The following is a description of a gene set: studied in species Mus musculus part of: Mitotic G1 phase and G1/S transition Reactome Pathway: G1/S Transition electronically inferred by orthology from the curated human pathway This event has been computationally inferred from an event that has been demonstrated in another species.<p>The inference is based on the homology mapping from PANTHER. Briefly, reactions for which all involved PhysicalEntities (in input, output and catalyst) have a mapped orthologue/paralogue (for complexes at least 75% of components must have a mapping) are inferred to the other species., and this is the list of marker genes: Rps27a, Psma7, Cables1, Psmc3, Mcm8, Mcm7, Cdc6, Psmb7, Psmb6, Psmb4, Pole, Psmc2, Psmc6, Psmd1, Psmc5, Cdkn1b, Psmd7 (NCBI Gene Id 17463), Ccna1, Prim1, Psmd13, Cul1, Psmb5, Rb1, Psmd12, Ccne2, Psma1, Cdc45, Mcm2, Mcm4, Pola1, Ccnd1, Dbf4, Cdk4, Ubb, Psmd6, Psma4, Ccnh (NCBI Gene Id 66671), Cdkn1a, Psma6 (proteasome subunit alpha 6), Psma3, Psmc4, Pola2, Orc1, Orc3, Psmc1, Wee1, Pole2, Psma5, Orc4, Cdc7, Rpa1, Ccne1, Ppp2r1b, Orc5 (origin recognition complex, subunit 5), Gmnn, Psma2